Given this list of marker genes H1f4, Dut, Samhd1, Dctpp1, St13, Hsp90aa1, Hsp90ab1, Trex1, here is a description of the gene set: Mouse Gene Set: GOMF_DEOXYRIBONUCLEOTIDE_BINDING Binding to a deoxyribonucleotide, any compound consisting of a deoxyribonucleoside that is esterified with (ortho)phosphate or an oligophosphate at any hydroxyl group on the deoxyribose moiety. species: Mus musculus